Given this list of marker genes COG8, COG2, STX6, STX16, NAPA, CUX1, MAN2A2, MAN2A1, ALPP, GOLGA5, NSF, CYTH3, GOSR1, RGP1, COG3, YKT6, COG1, NAPB, MAN1C1, STX5, RAB41, SNAP29, RIC1, CYTH4, TRIP11, RAB30, MAN1A1, GOSR2, NAPG, RAB39A, MAN1A2, VTI1A, CYTH2, CYTH1, RAB36 (RAB36, member RAS oncogene family), VPS45, BET1L, ARF1 (NCBI Gene Id 375), COG5, RAB33B, COG4, COG6, COG7, GOLIM4, here is a description of the gene set: species: Homo sapiens The mammalian Golgi consists of at least three biochemically distinct cisternae, cis-, medial- and trans. The structure and function of the Golgi are tightly interconnected, such that proteins that are required for protein transport through the Golgi are often also required for the organization of the Golgi stacks, and vice versa. Newly synthesized proteins from the ER and ERGIC are received at the cis face of the Golgi and flow through to the trans-Golgi before being released to the trans-Golgi network (TGN) for further secretion to the endolysosomal system, plasma membrane or extracellular region. Retrograde flow from the trans- to cis-cisternae moves endocytosed cargo from the extracellular region, the plasma membrane and the endolysosomal system back towards the ER. Intra-Golgi retrograde traffic also returns resident Golgi proteins to their appropriate cisternae, in this way facilitating cisternal remodeling or maturation. Intra-Golgi traffic in both directions is mediated by COPI carriers, with specificity of transport being determined at least in part by the complement of SNAREs, RABs and tethering proteins involved. Reactome Pathway: Intra-Golgi traffic part of: Intra-Golgi and retrograde Golgi-to-ER traffic